Given this list of marker genes Bap1, Usp22, Usp16 (NCBI Gene Id 76164), Usp3, Usp51, Mysm1, here is a description of the gene set: Mouse Gene Set: GOMF_HISTONE_H2A_DEUBIQUITINASE_ACTIVITY studied in species Mus musculus A histone deubiquitinase that cleaves ubiquitin from a histone H2A protein to which it is conjugated.